Given this list of marker genes MTRF1, C1QBP, SYCP2, CAND1, POLR2G, ATP2C1, GGCT (gamma-glutamylcyclotransferase), DEXI (Dexi homolog), THAP11, KANSL1L, CDC14B, FBL, DMXL1, HERC1, TRIM44, AIRIM, IL2RA, BACE2, HSPB8 (heat shock protein family B (small) member 8), TTC31, TUBB4B, RPL13A, RHEB, ITK, UAP1, FBP1, LINC01565, TARS1, THYN1, NFU1, DNAAF2, S1PR1, P2RX5, HGF (NCBI Gene Id 317720), MGA, CHPT1 (choline phosphotransferase 1), SS18, PMS2P5, PAFAH1B3, JCHAIN, MAPRE2, ITGB1, PEF1, NDUFAB1, PTPRO, ACAT1, DYNLL1, RARS1, BTK, ATF1, VGLL4, PNPO, UBA3, ADD3, GANAB, ARHGEF3, H2BC11, RFC4, DPP3, ANKRD17, DUSP3 (dual specificity phosphatase 3), AGA, ARL1, CD40LG, HINT1, ATP5F1B, SERBP1, GPN3, RAD17, PSMD7, PSMD1, CAPRIN2, CTNNBL1, GRB10, GRPR, OSGIN2, EIF2AK3 (NCBI Gene Id 9451), GPN1, MMD, IGLL3P, CLASP2, PTER, MOCS2, IMPACT, POLG (DNA polymerase gamma, catalytic subunit), POLR1D, DSCC1, NDUFA5, ZMYM6, SLF2, MYC, TTC13 (NCBI Gene Id 79573), GCLC, TPMT, YTHDC2, DPYSL2, RYK, BBS9, KLHL20, ADSL, RPAP2, ZFR, R3HDM1, PBX3, ZNF83, WDR7, RFX7, ANXA1, HOXA9, GTF3A, ZDHHC7, TCF12 (NCBI Gene Id 6938), FLT3LG, FUT8, PAN2, ADGRD2, RETREG3, NUP85, SEMA3C, PLAAT3, MAIP1, COPS7B, ABCC10, EXOC1, FDX1 (ferredoxin 1), CCNC, SGPP1 (NCBI Gene Id 81537), SMC4, OTUD3, CNTRL (NCBI Gene Id 11064), MEAK7, FIBP, NOC2L, ABRAXAS2, TRBC1 (NCBI Gene Id 28639), FNBP1, SNRNP27, SUPV3L1, FTO, API5, UQCRC2, ACVR1, ZMYND8, RIOX2, RNFT1, UBB, CLIP4, PTGES3, RND2, S100A10, MAZ, SRPRA, BHLHE40, SOD1, ARL2BP, SSB, N4BP2L1, SNRPF, MGST3, CUL2, AIMP1, MAP3K4, TRMT61B, PRPSAP1, SELENOT, SLC10A3, TFAP2B, PTPN9, MRPS30, TUBG1, BPESC1, RPN2, ASTE1, DARS2, YBX1, RPS27A (ribosomal protein S27a), PRPF19, DUSP12, RITA1, CCNT2, IARS1 (isoleucyl-tRNA synthetase 1), SRP19, XPO1, ZNF185, RPL4, FNBP4, METAP2, SRSF6, SMIM10L1, PPIA, TMSB10, CRYZ, PNP, TRMT1L, PDE6G, EEF1A1, RCL1, TCEA1, NUP37, FBXO21, here is a description of the gene set: In the present study we used Affymetrix oligonucleotide microarrays to produce gene transcription profiles for the major leukocyte types in humans. This comprehensive dataset enabled us to not only establish which genes were expressed in each leukocyte type, but also which genes were expressed in each subset after activation. The used of a comprehensive dataset of gene profiles from all the major human leukocyte subsets enabled a novel and powerful means for identification of genes associated with single leukocyte subsets, or different immune paradigms. Human Gene Set: GSE3982_NEUTROPHIL_VS_BASOPHIL_DN species: Homo sapiens from publication Jeffrey KL, Brummer T, Rolph MS, Liu SM, Callejas NA, Grumont RJ, Gillieron C, Mackay F, Grey S, Camps M, Rommel C, Gerondakis SD, Mackay CR (PMID 16474395) Genes down-regulated in comparison of neutrophils versus basophils.